Given this list of marker genes FRYL, ANP32E, CNOT9, POLA1, CENPA, TAF2, CPSF4, PAXIP1, TIMM44, DDX46, WDR62, TPP2, NELFA, SPRED2, SMG1, EIF5B, SEC23IP, PDXDC1, RFC5, EIF4E, ARHGAP11A, TTI1, C1orf216, AFF2, CAMK2G, UBE2V2, PIGF, HMGN4, TRIP13 (thyroid hormone receptor interactor 13), MARS1, MKI67, HNRNPL, HLTF, CSTF3, BMS1, TAF5 (NCBI Gene Id 6877), FANCI, LPGAT1, PPP5C, BRCA1, SYNJ2, MAD2L1, MPHOSPH6, COQ2, SPAST, FANCG, SIGMAR1, NFYB, DNA2, PHF10, CETN3, NUDT13, DIMT1 (NCBI Gene Id 27292), EEF1AKMT3, RRP9, MFN2, PEX3, RAP1A, OARD1, CLPX, HSPA13, KPNB1, TMEM11, TRIM27, NKRF, MYCBP, CDC7, CDK11A, JRK (NCBI Gene Id 8629), CCNF, PLK4, GTSE1, LARS2, PLEKHB1, MSH3, EXTL2, SCAMP1, ADGRL1, here is a description of the gene set: studied in species Homo sapiens Human Gene Set: MORF_CCNF Neighborhood of CCNF Neighborhood of CCNF cyclin F in the MORF expression compendium